Given this list of marker genes Anapc15-ps, Msx1 (msh homeobox 1), Ska1, Mos, Nuf2, Haspin, Spc25, Gja1, Drd3, Mki67 (antigen identified by monoclonal antibody Ki 67), Rgcc, Ccnb1-ps, Ins1, Cul9 (NCBI Gene Id 78309), Cdc42 (NCBI Gene Id 12540), Fgfr2, Apc, Anapc15, Fbxo43, Bora, Gpr3, Klhl22 (kelch-like 22), Pdgfb (platelet derived growth factor, B polypeptide), L3mbtl1, Pcid2, Insr, Bub1, Edn3, Zwint, Lcmt1, Cdk11b (NCBI Gene Id 12537), Cul7, Wnt5a, Igf1 (NCBI Gene Id 320499), Calr, Nfe2l1, Anapc11, Ube2b, Stra8, Cdca2, Tom1l1, Tex14 (NCBI Gene Id 97747), Aurkb, Rcc1 (regulator of chromosome condensation 1), Ccdc8, Fgfr3, Cenpe, Birc5, Cdca8, Anapc5, Sirt2, Bub3, Npm2, Zwilch, Ywhah, Osm, Xrcc3, Tgfa, Fbxo5, Ereg, Psma8 (proteasome subunit alpha 8), Meiosin, Dync1li1, Nusap1, Cdc16, Knl1 (NCBI Gene Id 76464), Hoxa13, Zfy2, Cdc20, Rad21, Wee2, Lif, Usp44, Sh2b1, Piwil2, Dazl, Plcb1, Fbxw5, Obsl1, Cul3, Mad1l1 (MAD1 mitotic arrest deficient 1-like 1), Camk2b, Epgn, Gen1, Dusp1, Il1b, Met, Rb1, Ttk, Msx2, Spc24, Pdgfrb, Nme6, Psmg2, Tnf, Tubg1, Wnt4 (NCBI Gene Id 22417), Spdl1, Kntc1, Prpf4b, Ins2, Trip13, Edn1 (endothelin 1), Cd28, Hormad1, Pde3a, Ik, Ccnb1, Arhgap33os, Egf, Tom1l2, Eif4g3, Nanos2, Mad2l1bp, Cdk5rap2, Dmrt1 (NCBI Gene Id 50796), Sphk1, Zw10, Bmp4, Fgf8, Cdc23, Smpd3, Bmp7, Phip, Btc, Incenp, Plk1, Pdxp, Fzr1, Prap1, Atm, Ska3, Lrp5, Cep192, Mtbp, Khdc3, Cav2, Zfp207, Esr1, Ndc80, Nsmce2, Mad2l1, Anapc7, Rps6ka2, Igf1r, Ube2c, Ooep, Nup62, Rad1, Chek1, Prdm9, Pebp1, Il1a, Tpr, Bub1b, Npr2, Igf2, Rad51ap1, here is a description of the gene set: Mouse Gene Set: GOBP_REGULATION_OF_NUCLEAR_DIVISION Any process that modulates the frequency, rate or extent of nuclear division, the partitioning of the nucleus and its genetic information. species: Mus musculus